The following is a description of a gene set: Mouse Gene Set: REACTOME_INHIBITION_OF_THE_PROTEOLYTIC_ACTIVITY_OF_APC_C_REQUIRED_FOR_THE_ONSET_OF_ANAPHASE_BY_MITOTIC_SPINDLE_CHECKPOINT_COMPONENTS Inhibition of the proteolytic activity of APC/C required for the onset of anaphase by mitotic spindle checkpoint components studied in species Mus musculus, and this is the list of marker genes: Bub1b, Cdc26, Anapc7, Anapc1, Anapc10, Anapc4, Mad2l1 (MAD2 mitotic arrest deficient-like 1), Cdc27, Anapc11, Ube2e1, Anapc2, Ube2c, Anapc16, Cdc20, Bub3, Anapc5, Ube2s, Cdc23, Cdc16, Ube2d1, Anapc15